Given this list of marker genes DGKE, IDH1, GNPAT (NCBI Gene Id 8443), PCYT1A, ENPP7, MTMR2, PLA2G1B, PLA2G10, INPP1, HTR2A, CHKA, PGAP4 (NCBI Gene Id 84302), INPP5A, PCYT1B, MVK, PLAAT4, LDLR, INPP5B, PIK3R3, DOLK, ETNPPL, PI4K2A, CWH43, FIG4, CDS1, CLN3, PRDX6, PI4KB, ISYNA1, PLSCR1, BPNT2, PITPNM2, PCYT2, PLCL2, GPAT3, CYP2W1, GATA6 (GATA binding protein 6), ABCA3, FITM2, PLAAT2, CLN8, CHAT, PTDSS1, MTMR12, MTMR8, IP6K2, PDGFA, TNFAIP8L3, PLCE1 (NCBI Gene Id 51196), LIPI, PI4K2B, FAR1, PGAP2, MBOAT7, DPM2, VAPA, AJUBA, ANGPTL3, PLCD1, ALOX15B, PTDSS2 (NCBI Gene Id 81490), SGPP1, DGKA, PIGL, CETP (NCBI Gene Id 1071), GPAA1, PLCG2, LIPH, HYCC2, NAPEPLD, PON1, ABCA8, APOC2, ETNK1, PNPLA6, LPCAT3, PIGB, ABHD3, IMPA2, HDHD5, ATM (NCBI Gene Id 8068), IDI1, MTM1, ITPKC, OSBPL5, NAAA, GPCPD1, SLC44A5, DHDDS, PIK3CB, PNPLA8, PCSK9, MIR30C1, OC90, PLBD2, PLA2G12A, PLCB2, ABHD12B, RAB38, DDHD1, MTMR3, BMX, TMEM86B, PLPPR1, SMG1, PIGX, PLD1, PLCB4, PLPPR5, MFSD2A, SMPD4, PLA2G5 (phospholipase A2 group V), ALOX15, TTC7A, IDI2, DGKZ, MTMR7, PISD (phosphatidylserine decarboxylase), INPP5E, PIK3CD, SH3GLB1, LPCAT1, TAFAZZIN, DGKH, DBI, PIGK, AGPAT1, PLA2G15, IMPA1, NR1H3, HADHA, SPATA18, PITPNM3, INPP4A, PI4KAP2, TMEM150A (NCBI Gene Id 200551), CHPT1, PIK3C3, OSBP, SH3YL1, SMPDL3A, PIGZ, PIGQ, ITPKA, SYNJ2, MTMR1, PNPLA3, GDPD3, TMEM38B, FABP5, HTR2B, GPAT2, PIP4P1, GPAT4, PLCL1, PIP5KL1, SCARB1, LCLAT1, LIPG, CHKB, PIGS, OSBPL10, PLA1A, PLAA, PIGV, INPP5K, PLA2G4B, GPAM, GGPS1, EFR3B, PLPPR3, TTC7B, PIGN, PIK3C2A, PIP4K2A, NR1H4, PLCG1, EFR3A, FADS1, ORMDL3, PIGM, MTMR4, NUS1, MTMR10, ADGRF5, ABHD4, THEM5, SMPDL3B, DPM1, MTMR9 (NCBI Gene Id 83651), PTEN, CEPT1, INPPL1, PLA2G4A, MPPE1, SGMS1, SGMS2, PLA2G4E, FDFT1, SCP2, PHB2, LCAT, PTPRQ, PEMT, GPLD1, PLAAT1, PLAAT5, BPNT1, SMPD2, PIGW, INPP4B, PPARD, HEXB, AGPAT3, AGPAT4, MTMR14, SAMD8, ENPP6 (NCBI Gene Id 133121), PGS1, GALR2, PIK3C2G, PIP4K2C, TPTE2, OSBPL8, IP6K3, PIP5K1A, FITM1, PNLIPRP2, SERINC1, DOLPP1, PLA2G2C, BLOC1S6, PIGO, DGKG, PLA2G6 (NCBI Gene Id 8398), SLC30A5, PITPNM1, INPP5J, APOA2, PLA2G4C, DPM3, PLA2G2E, PIGH, PLA2G2A, SERINC5, SPTLC2, PIK3R1, PTPMT1, LGALS13, LPIN1, SYNJ1, PLPP5, CHP1, PRKCD, OCRL, ETNK2, SELENOI (NCBI Gene Id 85465), GDPD1, CDS2, HMGCS1, PIK3CG, DGKB, ATG14, PIK3R4, BECN1, PIKFYVE, NR1H2 (nuclear receptor subfamily 1 group H member 2), PMVK, LIPC, APOA4, SMPD3, PIP5K1C, SERINC2, PLA2G4D, ENPP2, ABHD16B, DGKK, INPP5F, HYCC1, PLD2, PAFAH1B1, DGKD, PIGU, NKX2-1, SNCA, LPGAT1, GNB3, PI4KA, ACSL3, SERINC4, LPCAT2, ABHD16A, DGKQ, LPCAT4, APOC1, SPHK2, CHRM5, GDE1, PDGFB (NCBI Gene Id 5155), PIGA, PGAP1, PROCA1, FABP3, PIK3R5, HMGCS2, LPL, PIP4K2B, SERAC1, PIGF, VAC14, ACP6, PLCH2, DGKI, PLPPR2, PLA2G2F, SLC44A4, APOA1, CAPN2, MECP2, SPTLC1, MTMR6, XBP1, IPMK, SLC44A1, FLVCR1, IP6K1 (inositol hexakisphosphate kinase 1), AGPAT2, PLPP6, MBOAT2, TAMM41 (NCBI Gene Id 84207), ITPKB, PLCB1, PLPP4, PLPP2, PIP5K1B, PLB1 (NCBI Gene Id 388937), PIK3C2B, PLPP3, PLA2G3 (phospholipase A2 group III), ORMDL1, PLA2G7, PIGC, FDPS, PLAAT3 (NCBI Gene Id 11145), SLC44A3, PIP4P2, ABHD5 (abhydrolase domain containing 5, lysophosphatidic acid acyltransferase), PLPP1, PIK3CA, PNPLA7 (NCBI Gene Id 92716), PLCH1, PGP, UVRAG, ABHD6, PLA2G4F (NCBI Gene Id 255189), MBOAT1, PLCB3, ABCA2 (NCBI Gene Id 23153), ABHD8, PLPPR4, ABHD12, PLA2G2D, SACM1L, GPX4, PLBD1, PLA2G12B, CRLS1, SMPD1 (sphingomyelin phosphodiesterase 1), PIGY, INPP5D, MTMR11, PIGP, CDIPT, HTR2C, SRD5A3 (NCBI Gene Id 79644), DNAJC19, SLC44A2, PIPSL, PIGG, MVD, PGAP3, PIGT, AGPAT5, here is a description of the gene set: The chemical reactions and pathways involving phospholipids, any lipid containing phosphoric acid as a mono- or diester. Human Gene Set: GOBP_PHOSPHOLIPID_METABOLIC_PROCESS species: Homo sapiens